Given this list of marker genes Impdh1, Cad, Adsl, Ppat, Gart, Dhodh, Adss2, Umps, Adss1, Pfas, Paics, Gmps, Impdh2, Atic, here is a description of the gene set: Mouse Gene Set: REACTOME_NUCLEOTIDE_BIOSYNTHESIS species: Mus musculus Nucleotide biosynthesis